Given this list of marker genes Akr1a1, Gss, Gstm6, Mgst1 (microsomal glutathione S-transferase 1), Gstt2, Ggt1, Tpmt, Gsto2, Gstm7, Cndp2, Acsm1 (acyl-CoA synthetase medium-chain family member 1), Gstt1, Slc35b2, Gclc, Gstm1, Nnmt, Gsta3, Ugt3a2 (UDP glycosyltransferases 3 family, polypeptide A2), Sult2a1, Ugt2b1, Mtrr, Glyatl3, Ugdh, Ugt1a9, Ugt2a1, Gstk1, Acsm4, Ugt1a7c, Mat2a, Ggct, Ugt2b37, Sult1a1, Abhd10, Slc35d1, Comt, Gstm3, Sult1b1, Acsm5, Gstz1, Oplah, Gsto1, Gstm4, Gstp2, Sult4a1, N6amt1, Nat3, Ugp2, Ahcy, Ggt7, Gstm2, Tpst2, Ugt2a2, Ahcyl, Gsta2, Nat2, Chac1 (ChaC, cation transport regulator 1), Cyp1a2, Uxs1, Ggt6, Ugt1a8, Ugt1a6a, Slc26a1, Acsm2, Ugt1a2, Ugt3a1, Mgst2, Papss2, Ugt2b34, Slc26a2, Chac2, Bpnt1, Sult2b1, Bpnt2, As3mt, Sult1e1 (sulfotransferase family 1E, member 1), Trmt112 (tRNA methyltransferase 11-2), Sult2a2, Gsta13, Slc35b3, Sult1c2, Mgst3, Ugt2a3 (NCBI Gene Id 72094), Mat1a, Ugt2b5, Ggt5, Mtr (5-methyltetrahydrofolate-homocysteine methyltransferase), Glyat, Gclm, Ugt2b36, Ugt2b35, Esd, Mat2b (NCBI Gene Id 68881), Abhd14b, Gstp1, Ugt1a1, Gstm5, Gsta1, Gsta5, Sult6b1, Tpst1, Ugt2b38, Ugt1a5, Nat1, Hpgds, Papss1 (NCBI Gene Id 99599), Podxl2, here is a description of the gene set: species: Mus musculus Mouse Gene Set: REACTOME_PHASE_II_CONJUGATION_OF_COMPOUNDS Phase II - Conjugation of compounds